The following is a description of a gene set: The series of molecular signals that conveys information from the postsynapse to the nucleus via cytoskeletal transport of a protein from a postsynapse to the component to the nucleus where it affects biochemical processes that occur in the nucleus (e.g DNA transcription, mRNA splicing, or DNA/histone modifications). studied in species Homo sapiens Human Gene Set: GOBP_POSTSYNAPSE_TO_NUCLEUS_SIGNALING_PATHWAY, and this is the list of marker genes: KPNA1, RELA, STAT3, JAK2, RNF10, PRR7, WNT3A